Given this list of marker genes PMAIP1, CASP3, BAD, BBC3 (NCBI Gene Id 27113), BCL2L1, BAX, CYCS, CASP9, BAK1, BCL2, CASP7, APAF1, BCL2L11, here is a description of the gene set: Pathway Definition from KEGG: (PMAIP1,BBC3,BAD,BCL2L11) -| (BCL2,BCL2L1) -| (BAX,BAK1) -> CYCS == APAF1 -> CASP9 -> (CASP3,CASP7) studied in species Homo sapiens Intrinsic apoptotic pathway. Pathway ID: N00098. Pathway type: Reference. Pathway class: nt06524 Apoptosis. Human Gene Set: KEGG_MEDICUS_REFERENCE_INTRINSIC_APOPTOTIC_PATHWAY